The following is a description of a gene set: species: Homo sapiens Human Gene Set: COLE_BLOOD_FLUMIST_QUADRIVALENT_AGE_03_17YO_7DY_UP Genes up-regulated in blood 7d vs 0d in children (3-17) after exposure to Flumist Quadrivalent (LAIV), time point 7D. Comment: LAIV (live attenuated influenza vaccine) from publication Cole KS, Martin JM, Horne WT, Lin CJ, Nowalk MP, Alcorn JF, Zimmerman RK (PMID 29132989) BACKGROUND: In recent influenza seasons, the live attenuated influenza vaccine (LAIV) has not demonstrated the same level of vaccine effectiveness as that observed among children who received the inactivated influenza vaccine (IIV). To better understand this difference, this study compared the mRNA sequencing transcription profile (RNA seq) in children who received either IIV or LAIV. METHODS: Children 3-17years of age receiving quadrivalent influenza vaccine were enrolled. Blood samples were collected on Day 0 prior to vaccination and again on Day 7 (range 6-10days) following vaccination. Total RNA was isolated from PAXgene tubes and sequenced for a custom panel of 89 transcripts using the TruSeq Targeted RNA Expression method. Fold differences in normalized RNA seq counts from Day 0 to Day 7 were calculated, log<sub>2</sub> transformed and compared between the two vaccine groups. RESULTS: Of 72 children, 46 received IIV and 26 received LAIV. Following IIV vaccination, genes demonstrated significant differential expression at Day 7 (down-regulated). In contrast, following LAIV vaccination, genes demonstrated significant differential expression at Day 7 (5 up-regulated and 3 down-regulated). Only two genes demonstrated similar patterns of regulation in both groups. CONCLUSIONS: Differential regulation of genes was observed between 2015-16 LAIV and IIV recipients. These results help to elucidate the immune response to influenza vaccines and may be related to the difference in vaccine effectiveness observed in recent years between LAIV and IIV., and this is the list of marker genes: CXCL10, MX1, TNFSF10, IFIT3, IFI6